The following is a description of a gene set: studied in species Homo sapiens Human Gene Set: HP_MULTIPLE_LENTIGINES Multiple lentigines Presence of an unusually high number of lentigines (singular: lentigo), which are flat, tan to brown oval spots., and this is the list of marker genes: STK11, BRAF, NRAS, PDE11A, KITLG, RAF1, PTPN11, MAP2K2, SHOC2, SMARCAL1, DSTYK, MAP2K1, KRAS, PRKAR1A, MAPK1